The following is a description of a gene set: Mouse Gene Set: GOBP_NEGATIVE_REGULATION_OF_PROTEIN_TYROSINE_KINASE_ACTIVITY studied in species Mus musculus Any process that decreases the rate, frequency, or extent of protein tyrosine kinase activity., and this is the list of marker genes: Cav1, Tsg101, Socs4, Psen2, Ggnbp2, Psen1, Dusp22, Socs5, Cblc, Zfyve28, Lilrb4b, Mvp, Lilrb4a, Vps25, Gprc5a, Errfi1, Srcin1, Ptk6, Zgpat, Chmp6, Ptpn2, Hyal2